The following is a description of a gene set: Up-regulated in the cerebral cortex of aged (22 months) BALB/c mice, compared to young (2 months) controls from publication Jiang CH, Tsien JZ, Schultz PG, Hu Y (PMID 11172053) A better understanding of the molecular effects of aging in the brain may help to reveal important aspects of organismal aging, as well as processes that lead to age-related brain dysfunction. In this study, we have examined differences in gene expression in the hypothalamus and cortex of young and aged mice by using high-density oligonucleotide arrays. A number of key genes involved in neuronal structure and signaling are differentially expressed in both the aged hypothalamus and cortex, including synaptotagmin I, cAMP-dependent protein kinase C beta, apolipoprotein E, protein phosphatase 2A, and prostaglandin D. Misregulation of these proteins may contribute to age-related memory deficits and neurodegenerative diseases. In addition, many proteases that play essential roles in regulating neuropeptide metabolism, amyloid precursor protein processing, and neuronal apoptosis are up-regulated in the aged brain and likely contribute significantly to brain aging. Finally, a subset of these genes whose expression is affected by aging are oppositely affected by exposure of mice to an enriched environment, suggesting that these genes may play important roles in learning and memory. studied in species Mus musculus Mouse Gene Set: JIANG_AGING_CEREBRAL_CORTEX_UP, and this is the list of marker genes: Prdx1, Vim, Tpt1, C1qbp, Ccng1, Bcap29, Mbl1, Actb, Timp3, Col6a2 (collagen, type VI, alpha 2), Zfp51, H2az1, Rasgrf1, Sos2, Casp6, Pafah1b1, Scd1 (NCBI Gene Id 20249), Marcks (NCBI Gene Id 17118), Dck, Fkbp3, Gadd45b, Tra2b, Ube2e1, Epha7, Selenop, Cdc5l (NCBI Gene Id 71702), Rps24, Rpl5-ps1, Egr2, Prep, Rdx, Fah, Gria2, Slc25a4